Given this list of marker genes HBA1, HBQ1, HBE1, HBZ, HBG1, BPGM, HBA2, HBB, IPCEF1, CYGB, HBD, HBG2, MB, HBM, NGB, here is a description of the gene set: Human Gene Set: GOBP_OXYGEN_TRANSPORT species: Homo sapiens The directed movement of oxygen (O2) into, out of or within a cell, or between cells, by means of some agent such as a transporter or pore.